The following is a description of a gene set: studied in species Mus musculus Any process that activates or increases the frequency, rate, or extent of a T cell mediated immune response to tumor cell. Mouse Gene Set: GOBP_POSITIVE_REGULATION_OF_T_CELL_MEDIATED_IMMUNE_RESPONSE_TO_TUMOR_CELL, and this is the list of marker genes: Ywhag, Cd24a, Hspd1 (NCBI Gene Id 15510), Prkaa1, Klhl22, Slc22a13, Fbxo38, Mr1